The following is a description of a gene set: The aggregation, arrangement and bonding together of a set of components to form an inclusion body. species: Mus musculus Mouse Gene Set: GOBP_INCLUSION_BODY_ASSEMBLY, and this is the list of marker genes: Hspa2, Psmc5, Dnajb1, Hdac6, Vcp, Trim37, Dnajb6, Dlgap1, Apoe, Sorl1 (sortilin-related receptor, LDLR class A repeats-containing), Bag5, Clu, Dnajb2, Pmp22, Epg5, Cdc34, Psmc6, Mfsd8, Sncaip, Sacs, Dnajb8, Nox1, Ifnb1, Hsf1, Hap1, Prkn, Hspa1b, Psap, Cdc34b, Ubd, Dnaja4, Hsp90aa1